Given this list of marker genes Casp2, Casp1, Nsg1, Fgf2, Casp7, Myc (NCBI Gene Id 17869), Mmp2, Bcl2, Casp3, Mmp9, here is a description of the gene set: Mouse Gene Set: BAKER_HEMATOPOESIS_STAT1_TARGETS from publication Baker SJ, Rane SG, Reddy EP (PMID 17934481) STAT1 targets in hematopoetic signaling. Hematopoiesis is the cumulative result of intricately regulated signaling pathways that are mediated by cytokines and their receptors. Proper culmination of these diverse pathways forms the basis for an orderly generation of different cell types. Recent studies conducted over the past 10-15 years have revealed that hematopoietic cytokine receptor signaling is largely mediated by a family of tyrosine kinases termed Janus kinases (JAKs) and their downstream transcription factors termed STATs (signal transducers and activators of transcription). Aberration in these pathways, such as that caused by the recently identified JAK2V617F mutation, is an underlying cause for diseases such as leukemias and other myeloproliferative disorders. This recent discovery, when coupled with the fact that STATs are activated by oncoproteins such as BCR-ABL, underscores the importance of the JAK-STAT pathway in both normal cellular development and disease states. species: Mus musculus